Given this list of marker genes RNU4-2, IGF2, METTL27, ALG3, KCNMA1, FIBP, POU1F1, CLIP2, IPO8, GNE, TSHB, ROR2, GMPPB, GTF2IRD1, CPSF3, FOS, SLC5A5, CRPPA, HESX1, SMARCB1, POGZ, SAA1, BAZ1B, SMARCA4, POMT2, PSMB8, IDS, INPP5E, POMK, KLLN, AGA, KCNH5, PAX8 (NCBI Gene Id 7849), BSCL2, PLAGL1, CDCA7, ALG6, RMRP, PIK3C2A, VPS33A, PEX1, MT-TE, KCNQ1, IDUA, TRAF3IP2 (TRAF3 interacting protein 2), BUD23 (BUD23 rRNA methyltransferase and ribosome maturation factor), PIGW, DLK1, DNMT3B, GTF2I, PROP1, ALG8, GUSB, MBD5, TPO, POMT1, MAN2B1, CDKN1C, TBL2, PIK3CA, THRA, SDHB, RFC2, PPARG, SNRPN, FOXG1, RNF125, ARSB, FKBP6, SGCG, AMPD2, DUOX2, TG, TMEM270, LIMK1, UHRF1, USF3, POP1, IYD, NKX2-1, GLB1, LARGE1, INSR, ABCC8, GAA, GPR101, SDHC, MFN2, SLC26A4, CUL4B, NEK9, MEG3, EIF4H, ZFP57, HELLS, SEC23B, SDHD, AFF4, LIMS2, DUOXA2, CAV1, STX1A, NCF1, GPC4, VPS37D, LHX3, HEXB, POMGNT1, HYMAI, ACTB, AIP, ARID1A, FKRP, GNPTAB, GNS, LAMA2, AGPAT2, LHX4, AKT1, MED13L, EHMT1, BMP4, ELN, FUCA1, DVL1, IL6ST, SETBP1, CAVIN1, HS2ST1, TBCK, GPC3, KCNJ11, HNRNPK, PQBP1, UBE3A, WNT5A, SNX14, SNIP1, GTF2IRD2, FDX2, KCNQ1OT1, TSHR, CCDC47, KCNH1, PRKAG2, HRAS, RTL1, ZFX, PIGS (NCBI Gene Id 94005), KCNN3, ATRX, MAN2C1, PTEN, IFT140 (NCBI Gene Id 9742), NKX2-5, ZBTB24, ERLIN2, DNAJC30, FOXE1, ATP6V1B2, TRMU, here is a description of the gene set: Increased length and width of the tongue. species: Homo sapiens Human Gene Set: HP_MACROGLOSSIA Macroglossia